The following is a description of a gene set: studied in species Mus musculus Genes containing one or more binding sites for (Tnni2) in their promoter regions (TSS -1000,+100 bp) as identified by GTRD version 20.06 ChIP-seq harmonization. from publication Yevshin I, Sharipov R, Kolmykov S, Kondrakhin Y, Kolpakov F (PMID 30445619) Mouse Gene Set: TNNI2_TARGET_GENES, and this is the list of marker genes: Ank1, Gm15564, mt-Ty, Padi6, mt-Td, Gm13351, mt-Ta, mt-Tn, mt-Tc, Med16, Izumo1